The following is a description of a gene set: Human Gene Set: REACTOME_JOSEPHIN_DOMAIN_DUBS studied in species Homo sapiens Josephin domain DUBs, and this is the list of marker genes: JOSD1, UBA52, ATXN3L, UBB, ATXN3, UBC, RAD23B, PRKN, RPS27A, JOSD2, VCP, RAD23A